The following is a description of a gene set: Mouse Gene Set: TABULA_MURIS_SENIS_GONADAL_ADIPOSE_TISSUE_T_CELL_AGEING from publication Tabula Muris Consortium (PMID 32669714) species: Mus musculus, and this is the list of marker genes: Tle5, Cd3d, Gstp1, Pfn1, Gnb1, Cd3g, Tmsb10, Cfl1, Oaz1, Tmem176a, Bclaf1, Anp32e, Gsn, Rpl13a, Gas5, Ccr8, Dcn, Cd3e